The following is a description of a gene set: studied in species Homo sapiens Human Gene Set: GOBP_ESTABLISHMENT_OF_CENTROSOME_LOCALIZATION The directed movement of the centrosome to a specific location., and this is the list of marker genes: DLG1, PARD3, PARD3B, EZR, MAD2L1, CEP83, PKHD1, FHOD1, PAFAH1B1, MISP